The following is a description of a gene set: Adjuvanted vaccines afford invaluable protection against disease, and the molecular and cellular changes they induce offer direct insight into human immunobiology. Here we show that within 24 h of receiving adjuvanted swine flu vaccine, healthy individuals made expansive, complex molecular and cellular responses that included overt lymphoid as well as myeloid contributions. Unexpectedly, this early response was subtly but significantly different in people older than ~35 years. Wide-ranging adverse clinical events can seriously confound vaccine adoption, but whether there are immunological correlates of these is unknown. Here we identify a molecular signature of adverse events that was commonly associated with an existing B cell phenotype. Thus immunophenotypic variation among healthy humans may be manifest in complex pathophysiological responses. studied in species Homo sapiens Genes down-regulated in T cell 7d vs 1d in adults (18-64) after exposure to Pandemrix (A/California/7/09 (H1N1)), time point 7D. Comment: - roughly 60/40 female:male ratio, over 70% were Causasian Human Gene Set: SOBOLEV_T_CELL_PANDEMRIX_AGE_18_64YO_7DY_DN from publication Sobolev O, Binda E, O'Farrell S, Lorenc A, Pradines J, Huang Y, Duffner J, Schulz R, Cason J, Zambon M, Malim MH, Peakman M, Cope A, Capila I, Kaundinya GV, Hayday AC (PMID 26726811), and this is the list of marker genes: SLA2, CD3D, PLCG1, NFATC1, CD247, RASGRP2, LCK, PRF1, ZAP70, LAT, PAG1, CD8A, CD3E, RASGRP1, NFATC2, PRKCQ, MAP4K1, CD8B, NFATC3, FYN, CD3G